The following is a description of a gene set: The lysis or structural demise of the corpus luteum. During normal luteolysis, two closely related events occur. First, there is loss of the capacity to synthesize and secrete progesterone (functional luteolysis) followed by loss of the cells that comprise the corpus luteum (structural luteolysis). Preventing luteolysis is crucial to maintain pregnancy. studied in species Mus musculus Mouse Gene Set: GOBP_LUTEOLYSIS, and this is the list of marker genes: Notch1, Casp3, Casp2, Mmp19, Slit3